Given this list of marker genes FLT3, here is a description of the gene set: part of: Drug resistance of FLT3 mutants studied in species Homo sapiens Tandutinib, also known as MLN519, is a type II tyrosine kinase inhibitor with activity against FLT3. This pathway describes FLT3 mutants that are resistant to tandutinib-mediated inhibition. Reactome Pathway: tandutinib-resistant FLT3 mutants